Given this list of marker genes IGHMBP2, SLC25A44, DPM1, GGA1, DLX4, PSMB4, MTA2 (metastasis associated 1 family member 2), MED8 (NCBI Gene Id 115853), RARS1, GPANK1, ZDHHC5, TAF10, XIAP, GCC2, SNIP1, NCBP2AS2, ATP6V1D, MRPS23, COX7A2, ACVR2A, COX6B1, EIF2S1, ATP6V1E1, ZNF513, EIF1AD, MRPS21, COMMD6 (NCBI Gene Id 170622), FEV (NCBI Gene Id 54738), SF1, TIMM8A, PRKAB1, SNRPE, TFB2M, HSPH1, MAP4K1, RPL38, PTPRCAP, PCED1A, CCDC71, SEC11A, SRP54, CFAP57, PDAP1, RUVBL2, PEX6, ZNF597, MTF1, STK36, CSNK2B, RNF25, SEC61G, EIF2S3, PGS1, MRPL21, BCDIN3D, E2F4, EBNA1BP2, EIF3H, EXOC3L1 (exocyst complex component 3 like 1), SDF2, CHMP2A, RACK1, TWNK, CNST, BMS1, SUPT6H, RRAS, EIF3K, SMUG1, SEC24C, MRPL43, UBXN1, TTC17, GYS1, SZT2, PRPF3, TOR1A, BUD31, TMCO1, U2AF2, POMP, FARSA, RPL28, BANF1 (NCBI Gene Id 8815), PARVA, GLRX5, DDX55, FBXO38, MRPS18A, MBD1, UBA52, NCBP2, ZNF384, UBL5, TMEM38A, VTA1, CLASRP, THUMPD3, ZNF48, MOCS3, SEC61A1, RIC3, TRIM39, GIN1, VPS16, BAG6, UGGT1, TRMT11, G3BP2, EPN1, here is a description of the gene set: Genes having at least one occurrence of the highly conserved motif M21 GGAANCGGAANY in the regions spanning 4 kb centered on their transcription starting sites. The motif does not match any known transcription factor binding site. Comprehensive identification of all functional elements encoded in the human genome is a fundamental need in biomedical research. Here, we present a comparative analysis of the human, mouse, rat and dog genomes to create a systematic catalogue of common regulatory motifs in promoters and 3' untranslated regions (3' UTRs). The promoter analysis yields 174 candidate motifs, including most previously known transcription-factor binding sites and 105 new motifs. The 3'-UTR analysis yields 106 motifs likely to be involved in post-transcriptional regulation. Nearly one-half are associated with microRNAs (miRNAs), leading to the discovery of many new miRNA genes and their likely target genes. Our results suggest that previous estimates of the number of human miRNA genes were low, and that miRNAs regulate at least 20% of human genes. The overall results provide a systematic view of gene regulation in the human, which will be refined as additional mammalian genomes become available. from publication Xie X, Lu J, Kulbokas EJ, Golub TR, Mootha V, Lindblad-Toh K, Lander ES, Kellis M (PMID 15735639) Human Gene Set: GGAANCGGAANY_UNKNOWN studied in species Homo sapiens